The following is a description of a gene set: species: Homo sapiens A renal system process in which proteins are taken up from the collecting ducts, glomerulus and proximal and distal loops of the nephron. In non-mammalian species, absorption may occur in related structures (e.g. protein absorption is observed in nephrocytes in Drosophila, see ). Human Gene Set: GOBP_RENAL_PROTEIN_ABSORPTION, and this is the list of marker genes: EDNRB, CD2AP (NCBI Gene Id 25916), COMT, GAS6, AMN, GSN, ADIPOQ, EDNRA, KIRREL1